The following is a description of a gene set: IFNs are highly pleiotropic cytokines also endowed with marked anti-angiogenic activity. In this study, the mRNA expression profiles of endothelial cells (EC) exposed in vitro to IFN-alpha, IFN-beta, or IFN-gamma were determined. We found that in HUVEC as well as in other EC types genes were upregulated (>2-fold increase) by IFNs, including genes involved in the host response to RNA viruses, inflammation, and apoptosis. Interestingly, genes showed a >5-fold higher induction by IFN-alpha in EC compared to human fibroblasts; among them, the gene encoding the angiostatic chemokine CXCL11 was selectively induced by IFN-alpha in EC along with other genes associated with angiogenesis regulation, including CXCL10, TRAIL, and guanylate binding protein 1 (GBP-1). These transcriptional changes were confirmed and extended by quantitative PCR analysis and ELISA; whereas IFN-alpha and IFN-beta exerted virtually identical effects on transcriptome modulation, a differential gene regulation by type I and type II IFN emerged, especially as far as quantitative aspects were concerned. In vivo, IFN-alpha-producing tumors over-expressed murine CXCL10-11, GBP-1 and TRAIL, with evidence of CXCL11 production by tumor-associated EC. Overall, these findings improve our understanding of the anti-angiogenic effects of IFNs by showing that these cytokines trigger an anti-angiogenic transcriptional program in EC. Moreover, we suggest that quantitative differences in the magnitude of the transcriptional activation of IFNresponsive genes could form the basis for cell-specific transcriptional signatures. Human Gene Set: GSE3920_IFNA_VS_IFNB_TREATED_ENDOTHELIAL_CELL_DN studied in species Homo sapiens from publication Indraccolo S, Pfeffer U, Minuzzo S, Esposito G, Roni V, Mandruzzato S, Ferrari N, Anfosso L, Dell'Eva R, Noonan DM, Chieco-Bianchi L, Albini A, Amadori A (PMID 17202376) Genes down-regulated in endothelial cells: interferon alpha versus interferon beta., and this is the list of marker genes: NOTCH2, CD82, GZMB, CRAT, GATA1, IL10, FAM234A, GRK5, IL10RA, CCR3, PTPN11, LLGL2, MAP4K5, SPATA13, IL18RAP, FNIP2, PLXDC2, PLSCR4 (NCBI Gene Id 57088), ITGAX, PRPF6, PCYT1B, ENTPD1, PTGER4, KAT6A, GZMK, PTK2B, TACC1 (transforming acidic coiled-coil containing protein 1), MYO1D, MS4A4A, PRSS45P, LRRFIP2, JADE2, ZBTB38, CD70, TRAF3, DCLRE1C, LRRK1, DNMT3A, SMPDL3B, RPTOR, IL15, C1QTNF6, IGF2BP3, GDPD5, XYLT1, FRYL, APOBEC2, LCLAT1 (NCBI Gene Id 253558), MYH4 (myosin heavy chain 4), FYN, TRIM8, CMKLR1, MARCHF8, DTHD1, ATP6AP1L, GPR174, OSGEPL1, CD109, HRH4, GPM6B, PXN, SYTL2, SPRY2 (sprouty RTK signaling antagonist 2), LRRC32, DNASE1L3, CX3CR1, SEMA6D, NEDD4, TNFRSF18, DCLK1, PHETA2, CLEC2D, KCNJ8, CRIM1, ITSN1, ALAS2, MOSMO, ZEB2, TRAF2, IL1RL1, CPNE7, RNF111, SH3RF1, SEC16A, VSIG10L, IKZF3, FOXP1 (forkhead box P1), ADAMTS6, DMTF1 (cyclin D binding myb like transcription factor 1), KCNK10, FGR, TMBIM1, EPAS1, EOMES (NCBI Gene Id 8320), SLC4A1, NBR1, CYB5R3, PIK3R4, RAPGEF1, LAG3, LZTFL1, ZCCHC9, NSD3, FARP1, PODXL, KMT2B, NKG7, ITM2A, SAMD3 (NCBI Gene Id 154075), ITM2C, DAPK2, MRGPRF, ZAR1, KAT5, ADD2, ZBTB25, CACNG8, APLP1, GRAMD1B, LPIN2, CLDND2, CEP104, GLRX, SIGLEC5, ADGRE5 (adhesion G protein-coupled receptor E5), RNF216, KLRG1, SRGAP3, ACTG1 (NCBI Gene Id 71), GALNT3, DGKH, SORBS1, TIGIT, CASP1, SYNJ2, SULF2 (sulfatase 2), PTPN13, LASP1, CASS4, PIGC, CDC20B, KSR1, PIK3AP1, SETD5, PVR, ARHGAP25, FPGT, THEMIS2, ITPR1, KLRK1, PHOSPHO2, GNPTAB, GHRH, TNFSF13B, GFPT1 (NCBI Gene Id 2673), PDE1A, ZBTB7A, SLAMF7, GZMA, CHST15, PRR5L, ELAVL1, TRPC1 (transient receptor potential cation channel subfamily C member 1), NIBAN1, SPP1, VOPP1